Given this list of marker genes Setd2, Paf1, Sox17, Rtf1, Ctr9, Lama3, Dab2, Hmga2, Map2k1, Mmp8, Smad2, Mmp9, Pou5f1, Hsbp1, Col5a2, Fn1, Col8a1, Mixl1, Dusp1, Gata6, Col11a1, Inhba, Macroh2a1, Itga5, Col4a2, Tnrc6c, Nr0b1, Vtn, Sox2, Cdc73, Hnf1b, Dusp2, Dusp5, Nog, Lamb3, Sox7, Eomes, Col6a1 (NCBI Gene Id 12833), Mmp15, Itgav, Mesp1, Myh9, Nanog (NCBI Gene Id 71950), Nodal, Mmp14, Mmp2, Grb2, Dkk1, Lhx1, Brd3, Ctnnb1, Gata4, Col12a1, Col5a1, Dusp4, Leo1, here is a description of the gene set: studied in species Mus musculus Mouse Gene Set: GOBP_ENDODERM_FORMATION The formation of the endoderm during gastrulation.